The following is a description of a gene set: Mouse Gene Set: GOBP_NEURAL_CREST_CELL_FATE_COMMITMENT The process in which a cell becomes committed to become a neural crest cell. studied in species Mus musculus, and this is the list of marker genes: Sox9, Edn1, Gsc, Bmpr1a, Sfrp1, Ednra